Given this list of marker genes DKC1, POLE, RSPO1, CDKN1B, PTEN, NLRP1, APC, here is a description of the gene set: Human Gene Set: HP_EPITHELIAL_NEOPLASM Epithelial neoplasm studied in species Homo sapiens A benign or malignant neoplasm that arises from and is composed of epithelial cells. This category include adenomas, papillomas, and carcinomas.